The following is a description of a gene set: species: Homo sapiens Human Gene Set: MIR4666A_5P from publication Chen Y, Wang X (PMID 31504780) Genes predicted to be targets of miRBase v22 microRNA hsa-miR-4666a-5p in miRDB v6.0 with MirTarget v4 prediction scores > 80 (high confidence targets)., and this is the list of marker genes: NAMPT, MMRN1, ADK, ZNF281, AFF2, PRPF38B, LCP2, PDXK, ANKRD29, TNRC6B, NEXMIF, HAUS5, TMC5, G2E3, CD8A, EIF4G3, PTP4A1, CDK1, DR1, GAB1, EBAG9, TSPAN2 (NCBI Gene Id 10100), ADNP2, WAC, TENM2 (teneurin transmembrane protein 2), PTH, CCDC121, SDHAF2, ZCCHC2, DOP1A, PDK4, CPEB4, FILIP1, ST6GALNAC3, SLF1 (SMC5-SMC6 complex localization factor 1), ABRAXAS1, EIF4A3 (NCBI Gene Id 9775), TBX22, ELF2, PSD3, MAGEA9, HTATIP2, SLC13A1, MPP7, AFMID, QPCT, KATNA1, CHORDC1, SAV1, E2F7, SEPTIN7, IPO7, LAMB4, USP44, SLC6A19, ZNF136, GOLGA6L6, RGS13, DTHD1, PHF14, C1orf174, ACTN4, PAIP1, TMPO, HOXD1, ADAM22, STXBP4, GJA1, TMED5, PDLIM3, TXNDC17, GLUD2, LGSN, DDAH1, AP1S2, WDHD1, MAT2B, CDKN2C, UBE2B, SLFN5, UBE2V2 (ubiquitin conjugating enzyme E2 V2), HIPK1, SLC5A12, FOXRED1, TIA1, PUM1, ASCL1, SULF2, FAM149A, ZNF420 (NCBI Gene Id 338425), CCNG2, UBE2A, PIP4P2 (NCBI Gene Id 55529), IL31RA, TSLP, PCDH11X, ARL1 (ADP ribosylation factor like GTPase 1), SAMD4A, VWA8, MICU2, ATAD1, SLBP, TNFAIP8 (TNF alpha induced protein 8), EMC2, QKI, USP42, OXNAD1, ZNF284, SEL1L (NCBI Gene Id 6400), TMEM33, CLEC19A, HACE1, APC, EIF4B, L3MBTL1, TAGAP, PDCD4 (programmed cell death 4), RFX3, CERT1, KIF2A, DYNC1LI1, ZNF516, ADCYAP1R1, SSR3, CAMK1D, NTM (neurotrimin), GLUD1, PDSS1, ERLIN2, LDB2, FNDC3B, PPARGC1A, NIPA1, IFRD1, CDK7, SKP1, CHRNA3, WTAP, RAP2C, ZNF189 (NCBI Gene Id 7743), MTDH, CADM2, PCF11, KCTD16, SRC, ABCC9, N4BP2, SYT4, EIF1AX, PCBD2, FAM98A, ANAPC10, PHIP, FBN1, CANX, CDH11, TPP2, ISM1, KCNS3, DIAPH3, RAB38, BRWD3, SRD5A2, FGD5, KLF3, MED31, GCLC, PPP3R1, FBXO5, ZMAT3, FRY, NEK2, ING4, COPA, GOLGA6L1, SNX2, KIAA0586, PCDH11Y, ALCAM, GSTCD, WASF1, ZNF208, ABHD13, ZBTB11, PRCP, TTN, CACYBP, DIP2B, FRMD4B, ITPRIPL2, FBXO11, NR4A1, PSMF1, KIAA1217, ZNF507, AK7, HAUS2, WASL, LONRF3, PGM1, TNPO1, ZFP64, RAB5C, VPS13D, NSG1, ELAVL1, MEF2C, CNGB3, ZCCHC14, FCHO2, ZNF569, DLX5, RAPGEF2, SKA2, PAG1, SCN2A, ZEB2, GFRA1, CRPPA, EGLN1, USP3 (NCBI Gene Id 9960), ETNK1, ANGPT1, BOD1L1, UBR5, SLC2A13, MKX, SLC44A1, CAPRIN1, SEMA3D, SCLT1, JCAD, CEP126, DNAJB4, CDC14A, NTRK2, DDX3X, F2RL1, BNIP3L, EIF2A, RTN1, ARHGAP11A, PAFAH1B1, GUCY1A2, CD55, DHX35, OAZ2, MYLK3, LHFPL3, FZD3, ZNF514